Given this list of marker genes RTN1, RTN3, ZFYVE27, RTN2, ARL6IP1, RTN4, here is a description of the gene set: species: Homo sapiens The aggregation, arrangement and bonding together of a set of components to form the endoplasmic reticulum (ER) tubular network. The ER tubular network is the ER part that comprises the membranes with high curvature in cross-section. Human Gene Set: GOBP_ENDOPLASMIC_RETICULUM_TUBULAR_NETWORK_FORMATION